Given this list of marker genes FGFBP1, SIX1, MEGF10, CTNNB1, MEIS2, SOX15, ATF2, MALAT1, GATA6, PAX7, PPARD, MIR199A1, KCNA5, PAXBP1 (PAX3 and PAX7 binding protein 1), IGF1, FGF7, here is a description of the gene set: Human Gene Set: GOBP_POSITIVE_REGULATION_OF_MYOBLAST_PROLIFERATION species: Homo sapiens Any process that activates or increases the frequency, rate or extent of myoblast proliferation.